The following is a description of a gene set: species: Homo sapiens Human Gene Set: GOBP_REGULATION_OF_LUNG_BLOOD_PRESSURE The process that modulates the force with which blood travels through the lungs. The process is controlled by a balance of processes that increase pressure and decrease pressure., and this is the list of marker genes: SMAD3, MIR27B, BMPR2, MIR199A1, GCH1